The following is a description of a gene set: The process in which the vertebrate retina is organized into three laminae: the outer nuclear layer (ONL), which contains photoreceptor nuclei; the inner nuclear layer (INL), which contains amacrine, bipolar and horizontal cells; and the retinal ganglion cell (RGC) layer. Between the inner and outer nuclear layers, the outer plexiform layer (OPL) contains connections between the photoreceptors and bipolar and horizontal cells. The inner plexiform layer (IPL) is positioned between the INL and the ganglion cell layer and contains the dendrites of RGCs and processes of bipolar and amacrine cells. Spanning all layers of the retina are the radially oriented Mueller glia. Mouse Gene Set: GOBP_RETINA_LAYER_FORMATION studied in species Mus musculus, and this is the list of marker genes: Ptprm, Megf11, Lhx1, Tfap2b, Arl6, Dscam, Hipk1, Sdk1, Ndp, Prom1, Fat3, Slc1a1, Large1, Irx6, Sdk2, Hipk2, Tspan12, Atp8a2, Rdh13 (retinol dehydrogenase 13 (all-trans and 9-cis)), Crb1, Foxn4, Rs1, Fjx1, Ptf1a, Calb1